The following is a description of a gene set: Any process that activates or increases the frequency, rate or extent of T cell mediated cytotoxicity. Human Gene Set: GOBP_POSITIVE_REGULATION_OF_T_CELL_MEDIATED_CYTOTOXICITY studied in species Homo sapiens, and this is the list of marker genes: HLA-G, CYRIB, CD1D (NCBI Gene Id 912), ULBP3, HLA-E, CD1C, HLA-A, RAET1G, IL12B, ULBP1, IL23A (NCBI Gene Id 51561), TAP2, B2M, XCL1 (NCBI Gene Id 92337), IL12RB1, AZGP1, HLA-DRB1, CD1A (NCBI Gene Id 909), HLA-DRA, HLA-B, NECTIN2 (NCBI Gene Id 5819), MR1, IL23R, P2RX7 (NCBI Gene Id 5027), CD1B, IL12A, HLA-F, FADD, HLA-C (major histocompatibility complex, class I, C), CD1E, ULBP2, PVR, RAET1E, STX7, HLA-H, PTPRC, RAET1L, SLC22A13